The following is a description of a gene set: studied in species Mus musculus Mouse Gene Set: chr14E4, and this is the list of marker genes: Gm20167, Gm5209, Dct, Rpl19-ps5, Gm4681, Gm27198, Gm18076, 4933431J24Rik, Gm6087, Gm5672, Dzip1, Hs6st3, Gpc5, Mir6239, Gm26679, Gm6212, Gm23302, Mir19a, Tpm3-rs7, Gm19223, Gm26791, Gm32093, Gm19829, 1700100I10Rik, Gm16835, Mir17, Uggt2, Sox21os1, Oxgr1, Gm49008, Mir18, 1700006F04Rik, Gm23669, 4930524C18Rik, Rap2a, Gm9376 (NCBI Gene Id 675109), Slitrk5, Gm18367 (NCBI Gene Id 100417023), Gm18580, Gm4822, Gm41253, Mir20a, Mir6391, Gm18369, 4930404K13Rik, Cldn10, Sox21, Mir92-1, Mbnl2, Gm48992, Gpc6, Gm4486, Mir17hg, Mir19b-1 (NCBI Gene Id 751527), 4930505G20Rik, 4930435M08Rik, Abcc4, Gpr180, Tgds, Gm22764, Gm20127, Gm31072, Mir6241, Gm4487, Gm9391, Gm22379, Dnajc3